Given this list of marker genes PTF1A, FKTN, ATP7A, WNT7A, LPAR1, CDK5R2, KAT2A, ATIC (5-aminoimidazole-4-carboxamide ribonucleotide formyltransferase/IMP cyclohydrolase), PRKG1, GBA1 (glucosylceramidase beta 1), LDB1, B4GALT2, CDK5, NANOS1, CLP1, ABL1, NEUROD2, TP53, TTC21B, HNRNPD, DAB1, SEMA4C, GLI2, SCRIB, COMT, KNDC1, KCNE1, PAK1, SMO, COQ8B, OPHN1, PTBP2, TRNP1, GRID2, DLL1, AARS1, SDF4, PROX1, NRXN1, BCL2, CBLN1, ARCN1, GLI1, HSPA5, CBS, SSTR1, RERE, NCSTN, MYH10, TTLL1, MAP2K1, HERC1, RORA, NAGLU, HOXB1, NAV2, PHOX2A, CD3E, EN1, CEND1, SKOR2, FOXP2, CRK, GDF10, ZNF365, ATRN, UQCRQ, SCN5A (sodium voltage-gated channel alpha subunit 5), GNPAT, WNT1, SLC25A46 (NCBI Gene Id 91137), SEC24B, ENSG00000274276, GBX2, NLGN4X, ASCL1, SERPINE2, KLHL1, SPTBN2, GABRB3, PDSS2, RPGRIP1L, MYO16, PSEN1, NEUROD1, KCNC1, KIF14, LHX5 (NCBI Gene Id 64211), OGDH, LHX1, WHRN, SEZ6, AGTPBP1, FAIM2, OTX1, NCOR2, CRKL, HAP1, PTPRS, GART, CNTN1 (NCBI Gene Id 1272), LMX1A, MT-CO1, NCOA1, MECP2, FZD4, EZH2, FOXC1, ATF2, PTPN11, TTBK2, GPX4, ABAT, TUBA1A, CDK5R1, MDK (midkine), FCGR2B, PIANP, MT-ND4, here is a description of the gene set: Human Gene Set: GOBP_METENCEPHALON_DEVELOPMENT species: Homo sapiens The process whose specific outcome is the progression of the metencephalon over time, from its formation to the mature structure.